The following is a description of a gene set: studied in species Homo sapiens Quercetin and Nf-kB / AP-1 induced apoptosis Human Gene Set: WP_QUERCETIN_AND_NFKB_AP1_INDUCED_APOPTOSIS, and this is the list of marker genes: NFKB1 (NCBI Gene Id 4790), IKBKB, NOS1, MAFG, FOS, NFE2L2, NFKBIA, ACOX2, MMP1, MT-CO1, MAFK, CYP2A6, VEGFA, KEAP1, JUN, PTGS2